Given this list of marker genes DLD, RARS1, DDX52, MCM10, IL1RL1, CAPZA2, CINP, TCP1, ITGA1, BLTP3B, DNAJC15, KNL1, CLNS1A, POLR2D (NCBI Gene Id 9393), PDHX, MIX23, CCNB2, HMGCS1, COX7A2, LTV1, GOLM2, MRPL1, UCHL5, RAD51, IMMT, USP3 (ubiquitin specific peptidase 3), MCM3, ATAD5, EPRS1, CDCA3, MTFR2, TMPO, MRPS28, MT2A, COX10, EXO1, BRIP1, POLR2B, AP1S1, COX5B, HMGB3, SYCE2, UBE2V1, KCTD20, RBM3, LY6E, DKC1, PALS2, PRELID1, PLK4, BLMH, MTMR1, HAT1, BZW1, PRMT5, OTULIN, RACGAP1 (NCBI Gene Id 94651), NAA50, HSD17B12, DEPDC1, MT1A, KLRK1, ARL6IP4, YBX1, EMB, E2F8, PSMD12, GALNT3, TIMM50, COMMD9, SAE1, GTF2F1, PGAM1, SDHD, CENPP, ESM1, ANXA2, WEE1, C1QBP, HMGN2, VIM (vimentin), CIRBP (cold inducible RNA binding protein), SERPINB9, PPP1R8, IPO5, ADSS2, NRM, HMGB1, PA2G4, FIGNL1, THYN1, FMC1, KLF11, SEPTIN2, PRKAG1, NUP133, SNRPA (small nuclear ribonucleoprotein polypeptide A), EXOSC9, ATP8B4, KIF23, CNOT9, ATR, RRP15, EIF2A, EIF1AX (eukaryotic translation initiation factor 1A X-linked, NCBI Gene Id 83754), CSF2, TRIP13, RRM2, PSMC1, SNRPD1, MEMO1, COX7B, WDR76, DTL, IGF2BP3, AKAP1, BIRC5, DBI, STMN1, UBA2, PPAT (NCBI Gene Id 5471), CPSF6, NOC3L, SRP72, H2BC14, IRAK3, SLC30A4, COPS5 (NCBI Gene Id 10987), SATB1, CEP83, ETFDH, IL7R, RPL10, IL2RA, CLNK, DPY19L1 (dpy-19 like C-mannosyltransferase 1), SPC24, GMPS, FKBP5, PMF1, TAGLN2, RRAS2, UTP20, PLAA, MRPS14, CDC7, DDX21, CHML, CENPH, RPF2, HARS1, GGH (NCBI Gene Id 8836), BRI3BP, CDC25C, MAD2L1, PSMB2, MCM4, PLA2G12A, KLHDC4, THY1, SNRPA1, H4C6, TOMM5, RRM1, MTPN, TACC3, IL18R1, XPO1, LRPPRC, CDC6, TPI1, RPA3, ZBTB32, ACAA2 (acetyl-CoA acyltransferase 2), DDX1, SLC35A3, WDR12 (NCBI Gene Id 55759), BANF1, AHCY, RNMT, MRPS9, here is a description of the gene set: The development, homeostasis and function of B lymphocytes involve multiple rounds of B cell receptor (BCR)-controlled proliferation and prolonged maintenance. We analyzed the role of transcription factor Zfx, a recently identified regulator of stem cell maintenance, in B cell development and homeostasis. Conditional Zfx deletion in the bone marrow blocked B cell development at the pre-BCR selection checkpoint. Zfx deficiency in peripheral B cells caused impaired generation of the B-1 cell lineage, accelerated B cell turnover, depletion of mature recirculating cells, and delayed T-dependent antibody responses. Zfx-deficient B cells showed normal proximal BCR signaling, but impaired BCR-induced proliferation and survival. This was accompanied by aberrantly enhanced and prolonged integrated stress response, and delayed induction of Cyclin D2 and Bcl-xL proteins. Thus, Zfx restrains the stress response and couples antigen receptor signaling to B cell expansion and maintenance during development and peripheral homeostasis. species: Homo sapiens Genes up-regulated in B lymphocytes stimulated by anti-IgM for 2h: wildtype versus ZFX knockout. from publication Arenzana TL, Smith-Raska MR, Reizis B (PMID 19329779) Human Gene Set: GSE13547_WT_VS_ZFX_KO_BCELL_ANTI_IGM_STIM_2H_UP